The following is a description of a gene set: The process in which a relatively unspecialized cell acquires specialized features of a neuroblast. There are at least four stages through which the pluripotent cells of epiblast or blastula become neuroblasts. species: Mus musculus Mouse Gene Set: GOBP_NEUROBLAST_DIFFERENTIATION, and this is the list of marker genes: Dlx2, Dlx1, Six3, Tafa1, Ascl1, Nfix, Bche, Notch3, Kctd11